The following is a description of a gene set: studied in species Mus musculus Mouse Gene Set: GOMF_L_ASCORBIC_ACID_BINDING Binding to L-ascorbic acid, (2R)-2--4-hydroxy-5-oxo-2,5-dihydrofuran-3-olate; L-ascorbic acid is vitamin C and has co-factor and anti-oxidant activities in many species., and this is the list of marker genes: P3h1, Egln3, Plod3, Pam, Plod1, Egln1 (egl-9 family hypoxia-inducible factor 1), Dbh, P4htm, P4ha1, Ogfod3, P3h3, Egln2, Ogfod2, P4ha2, Phyh, P4ha3, P3h2, Plod2, Ogfod1